Given this list of marker genes TRPS1, DLK1, TWIST2, CDH11, NAA10, RTL1, SCNM1, FOXP1, MEG3, EED, here is a description of the gene set: Human Gene Set: HP_CHIN_WITH_HORIZONTAL_CREASE Horizontal crease or fold situated below the vermilion border of the lower lip and above the fatty pad of the chin, with the face at rest. Chin with horizontal crease studied in species Homo sapiens